Given this list of marker genes EGR2, SEMA3F, BMPR1A, HOXB1, HSPA5, NRP2, DAB1, HOXB2, RAC1, DLL1, SEMA3A, PAX2, NRP1, PLXNA3, TFAP2A, KIF14, KCNA2, PLXNA4, here is a description of the gene set: studied in species Homo sapiens The process that gives rise to the configuration of the constituent parts of an anatomical structure. This process pertains to the physical shaping of a rudimentary structure. Anatomical structures can be macroscopic such as a carpel, or microscopic such as an acrosome. Human Gene Set: GOBP_ANATOMICAL_STRUCTURE_ARRANGEMENT